The following is a description of a gene set: Human Gene Set: GOBP_SPHINGOMYELIN_METABOLIC_PROCESS The chemical reactions and pathways involving sphingomyelin, N-acyl-4-sphingenyl-1-O-phosphorylcholine, any of a class of phospholipids in which the amino group of sphingosine is in amide linkage with one of several fatty acids, while the terminal hydroxyl group of sphingosine is esterified to phosphorylcholine. species: Homo sapiens, and this is the list of marker genes: SMPDL3B, PEMT, ORMDL1, SGMS2, SMPD3, ABCA8, SPTLC2 (NCBI Gene Id 9517), OSBP, SMPD2, SPTLC1, ORMDL3, SGMS1, SMPDL3A, SMPD4, PRKCD, ENPP7, SMPD1, ABCA2, VAPA, SAMD8